Given this list of marker genes pp1a, ISCU, rep, here is a description of the gene set: Reactome Pathway: Maturation of replicase proteins_9694301 This COVID-19 pathway has been created by a combination of computational inference from SARS-CoV-1 data (https://reactome.org/documentation/inferred-events) and manual curation, as described in the summation for the overall SARS-CoV-2 infection pathway.<br><br>Production of polyprotein fragments (so called replicase proteins) involves the repeated autocleavage of the polyprotein, liberating the two endopeptidases that finally cleave all fragments efficiently. Only nsp3 and nsp4 are post-translationally modified, they are glycosylated. studied in species Homo sapiens part of: Translation of Replicase and Assembly of the Replication Transcription Complex